Given this list of marker genes Chrnb2 (NCBI Gene Id 11444), Il6, Alb, Btbd9, Ada, Ghrh, Parp1, Adora1, Mtnr1b, Casp1, Kcna2, Ptger3, Ghrl, Npy2r, Ptger4, Ghrhr, here is a description of the gene set: All sleep stages in the circadian sleep/wake cycle other than REM sleep. These stages are characterized by a slowing of brain waves and other physiological functions. studied in species Mus musculus Mouse Gene Set: GOBP_CIRCADIAN_SLEEP_WAKE_CYCLE_NON_REM_SLEEP